The following is a description of a gene set: Mouse Gene Set: GOBP_PROTEIN_IMPORT studied in species Mus musculus The targeting and directed movement of proteins into a cell or organelle. Not all import involves an initial targeting event., and this is the list of marker genes: Apoe, Prf1, App, Gpihbp1, Arhgef5, B4galnt2, Lrp2, Hnrnpm, Wdr72, Snx33, Fkrp, Tomt, Clu, Chrd, Fcgr4